Given this list of marker genes PTGER4, SOX2, ZNF467, FAM110C, CDYL2, ID1, PPFIBP2, BIK, REL, GRHL3, RPRM, RGS2, ENC1, BTG2, EDN2, TGFB2, ID3, C9orf152, TENT5B, BMF, NUAK1, TGFB3, VEGFC, SH3BP4, SGCG, RND3, RIN2, STON1, ELF5, PIK3R3, KCNJ8, DDIT4, PDP1, CREBRF (CREB3 regulatory factor), TP53INP1, LNX1, HILPDA, RNF43, CCNG2, FAM171B (NCBI Gene Id 165215), DRAM1, TM4SF1, TUFT1, PLK2, LIMA1, EFNA1, ARHGEF37, BAMBI, PLEKHF2, LYPD3, RNF144B, CFAP206, EGLN3, ARID5B, AMIGO2, S1PR3, GRAMD2B, SPRY1, SOCS2, ST8SIA4, ID2, HCAR1, HCAR2, FAM107B, GRB7, IL1R1, TNFRSF11B, SP6, ARL4D, RUNDC3B, CCN2, SMAD6, LIPH, DRD1, CMYA5, BLNK, RAB27B, here is a description of the gene set: As one of the most successful cancer therapeutic targets, estrogen receptor-alpha (ER/ESR1) has been extensively studied over the past few decades. Sequencing technological advances have enabled genome-wide analysis of ER action. However, comparison of individual studies is limited by different experimental designs, and few meta-analyses are available. Here, by ingesting large amount of E2-related transcriptomic data sets in breast cancer cell lines, we identified gene expression changes across 66 RNA-seq and 80 microarray experiments based upon the E2-induced fold change in gene expression. Among the 146 merged transcriptomic datasets, 27 different time points were annotated spanning from 5 minutes to 600 hours of estrogen stimulation. We separated all the comparisons into three signatures of duration: EstroGene_Early (≤6 hours, n = 58), EstroGene_Mid (6-24 hours, n = 44) and EstroGene_Late (≥ 24 hours, n = 44). Upregulated and downregulated genes present in the top 10th percentile of regulated genes in each individual study, and consistently present across at least 50% of studies at each time period, were extracted from each signature (early, mid, and late) and intersected accordingly. We identified 165, 59 and genes representing early, mid, and late estrogen response signatures, respectively. studied in species Homo sapiens from publication Li Z, Li T, Yates ME, Wu Y, Ferber A, Chen L, Brown DD, Carroll JS, Sikora MJ, Tseng GC, Oesterreich S, Lee AV (PMID 37272757) Human Gene Set: LI_ESTROGENE_EARLY_E2_RESPONSE_DN High confident estrogen down-regulated genes in early treatment duration (≤6 hours) in breast cancer cells merged from 58 NGS datasets-based comparisons (10% topmost down-regulated genes and consistent in at least 40% comparisons).